The following is a description of a gene set: species: Mus musculus The chemical reactions and pathways resulting in the breakdown of compounds that contain an indole (2,3-benzopyrrole) skeleton. Mouse Gene Set: GOBP_INDOLE_CONTAINING_COMPOUND_CATABOLIC_PROCESS, and this is the list of marker genes: Ido1, Tdo2, Haao (3-hydroxyanthranilate 3,4-dioxygenase), Il4i1, Acmsd, Ido2, Afmid, Kmo, Kynu